Given this list of marker genes GPC4, PPP3CA, ARHGEF9, ASXL3, RB1, ASXL1, LMNB1, DPM1, ACTB, FRMPD4, DPH2, FLCN, GPC3, PTCH1, SLC6A9, ERI1, ADNP, NUP188, GLI3, USP7 (ubiquitin specific peptidase 7), C2CD3, DPM2, GTF2H5, HUWE1, CHD4, EFTUD2, DPF2, DPH1, MEGF8, MYSM1, LMNB2, PDHX, ACTG1, FGFR2, FGFR1, SOX4, IFT140, MSX2, FREM1, PLOD1, IL11RA, FLI1, CD96, ZIC2, GNPTAB, here is a description of the gene set: studied in species Homo sapiens Trigonocephaly Human Gene Set: HP_TRIGONOCEPHALY Wedge-shaped, or triangular head, with the apex of the triangle at the midline of the forehead and the base of the triangle at the occiput.